Given this list of marker genes Urah, Urad, Pnp, Uox, Nt5c2, Nt5c1a, Nt5c, Xdh, here is a description of the gene set: Mouse Gene Set: GOBP_IMP_CATABOLIC_PROCESS The chemical reactions and pathways resulting in the breakdown of IMP, inosine monophosphate. studied in species Mus musculus